The following is a description of a gene set: Genes down-regulated in E12.5 forelimb buds with POR knockout. Mouse Gene Set: SCHMIDT_POR_TARGETS_IN_LIMB_BUD_DN studied in species Mus musculus from publication Schmidt K, Hughes C, Chudek JA, Goodyear SR, Aspden RM, Talbot R, Gundersen TE, Blomhoff R, Henderson C, Wolf CR, Tickle C (PMID 19273610) Cytochrome P450 oxidoreductase (POR) is the obligate electron donor for all microsomal cytochrome P450 enzymes, which catalyze the metabolism of a wide spectrum of xenobiotic and endobiotic compounds. Point mutations in POR have been found recently in patients with Antley-Bixler-like syndrome, which includes limb skeletal defects. In order to study P450 function during limb and skeletal development, we deleted POR specifically in mouse limb bud mesenchyme. Forelimbs and hind limbs in conditional knockout (CKO) mice were short with thin skeletal elements and fused joints. POR deletion occurred earlier in forelimbs than in hind limbs, leading additionally to soft tissue syndactyly and loss of wrist elements and phalanges due to changes in growth, cell death, and skeletal segmentation. Transcriptional analysis of E12.5 mouse forelimb buds demonstrated the expression of P450s involved in retinoic acid, cholesterol, and arachidonic acid metabolism. Biochemical analysis of CKO limbs confirmed retinoic acid excess. In CKO limbs, expression of genes throughout the whole cholesterol biosynthetic pathway was upregulated, and cholesterol deficiency can explain most aspects of the phenotype. Thus, cellular POR-dependent cholesterol synthesis is essential during limb and skeletal development. Modulation of P450 activity could contribute to susceptibility of the embryo and developing organs to teratogenesis., and this is the list of marker genes: Chrna5, Aldh1a2, Chmp4c, Msx2, Naip1, Cpa3, Ifitm1, Abca1